The following is a description of a gene set: Human Gene Set: GOCC_CLATHRIN_ADAPTOR_COMPLEX species: Homo sapiens A membrane coat adaptor complex that links clathrin to a membrane., and this is the list of marker genes: AP2A1 (adaptor related protein complex 2 subunit alpha 1, NCBI Gene Id 92649), STON1, AP4B1, AP2M1, AP2S1, STON2, AP1M2, AFTPH, AP1S3, AP1G1, AP3M2, AP2B1, SGIP1, SYNRG, AP1S2, AP3M1, AP3B1, SLC18A3, AP1G2, AP2A2, CLBA1, BTBD8, AP4M1, AP1B1, EPS15, AP1M1, AP1S1, TBC1D5